Given this list of marker genes ASAH1, PSAP, LRP5, NPC1, TNFRSF11B, GNPTAB, CA2, CLCN7, OCRL, here is a description of the gene set: studied in species Homo sapiens Human Gene Set: HP_ABNORMALITY_OF_LYSOSOMAL_METABOLISM Abnormality of lysosomal metabolism